The following is a description of a gene set: Genes down-regulated in Pmel-1 CD8 T cells: naïve versus primed with cognate antigen (gp100) and IL2. studied in species Homo sapiens The expansion, trafficking and functional effectiveness of adoptively transferred CD8+ T-cells play a critical role in mediating effective anti-tumor immunity. However, the mechanisms which program the highly proliferative and functional state of CD8+ T-cells are not completely understood. We hypothesized that IL-12, a cytokine commonly induced by TLR activation, could enhance T-cell priming by altering responsiveness to antigen and cytokines. Priming of tumor specific CD8+ T-cells in the presence of IL-12 induced the acquisition of a 'polyfunctional' effector response and increased the generation of memory cells. Moreover, IL-12 priming also promoted high levels of the IL-2 receptor alpha-chain (CD25) and robust IL-2 mediated activation of STAT5. This sensitivity to IL-2 translated into enhanced in vivo proliferation of adoptively transferred CD8+ T-cells. Furthermore, real-time, in vivo imaging of T-cell trafficking confirmed the ability of IL-12 priming to drive in vivo proliferation. IL-12 priming enhanced the anti-tumor function of adoptively transferred cells by reducing established subcutaneous tumor burden, and significantly increasing survival in an established intracranial tumor model. Finally, IL-12 priming of human PBMCs generates tumor specific T-cells phenotypically and functionally similar to IL-12 primed Pmel-1 T-cells. These results highlight IL-12 as an important mediator of CD8+ T-cell effector function and anti-tumor immunity. Human Gene Set: GSE22443_NAIVE_VS_ACT_AND_IL2_TREATED_CD8_TCELL_DN from publication Lisiero DN, Soto H, Liau LM, Prins RM (PMID 21430221), and this is the list of marker genes: C4BPA, ACYP2, CFTR, CRYAA, MTNR1A, ALKBH5, EPYC (epiphycan), CALB1, NCKAP1, KRT86, CNN3, S100A1, CPD, CALB2, DNAJB4 (DnaJ heat shock protein family (Hsp40) member B4), DMBT1, LBP, PPL, DLL1, HDLBP, MST1R, SAMD10, CXCL3, COL6A3, ZFPM1, FZD3, SEPTIN4, MYH14, SYT11, PTH, SPTBN2 (NCBI Gene Id 6712), COPRS, SEZ6, BEX4, CTPS2, FOSB, PKP1, ITIH4, MT1E, GC (NCBI Gene Id 2638), TNNI1, MYO5B, IL9, PENK, ANKRD1, ALDH1A3, ERRFI1, ANGPT2, PFKM, PAX1, CRYL1 (NCBI Gene Id 51084), USP2, LAMC2, CTSV, CH25H, KHDC1L, PTGES, SERPINB1, C2, SLC25A51, ZG16, DAO, COPZ2, DDR1, ACOT2, BIRC2, SLC25A25, BTBD3, PAPSS1, P4HA2, CST8, LTBP4, MGST1, CCDC80, CYP1A2, CRYGS, DLG3, SLC1A1, WNT11, AGRN, TMEM43, GSTM3 (NCBI Gene Id 2947), C19orf48P, ENO2, SLC38A4, GRPEL2, SFN, NAV2, CDR2 (cerebellar degeneration related protein 2), ANKH, PAWR, BLK, OCM2, MLF1, FN1, H19, CSF2, SLC10A6, PLEKHA7, KDM3A, KRT18, IAPP, LXN, CYP24A1, ASNS, BMX, INHBB, HP, BPIFA2, SPRYD7, MYCN, HMOX1, ECHS1, IL12A, SH3YL1, CALML5, HEBP1, ADPRM, SIX1, F11R, HEY1 (hes related family bHLH transcription factor with YRPW motif 1), POU2F3, LMAN1, SLC51A, AMOT, SLC22A17, SLC5A1, IKBKE, COL14A1, SMPDL3A, ING1, IGFALS, KRT12, FHL1, BMP1, PDGFRB, CAPN5, ZNF35, CDC42EP4, ENTPD2, SEMA3F, TMEM30B, RNF6, TEK, PIGR, ELOVL6, BCKDHB, PAX9, TNFRSF9, VOPP1, TRO, IFT81, ABCC2, MAL, EDN1, ZFR2, NES, PREPL, PMP22, PROM1, TSPAN6, ACTC1, HADH, DTX1, GJA1, GAS1, TSC22D1, MEIS1, C3, ARHGEF28, MTTP, ELN, ABCC8, HBB, C16orf74, CTSF, ELF3, SELE, SEC61A2, FAM83G, IFITM3, CMTM8, CDH9, CDS2, ACHE, ITGB4, ABCD3, DUSP16, CPXM2, CYSTM1, TGFB3, COL4A1, COL18A1, FAM83H, CYB561, RHBDL3 (NCBI Gene Id 162494), TRIM13, ID3, DENND2B, CEBPB